The following is a description of a gene set: species: Homo sapiens Human Gene Set: GOBP_CELL_PROLIFERATION_INVOLVED_IN_HEART_MORPHOGENESIS The multiplication or reproduction of cells, resulting in the expansion of a cell population that contributes to the shaping of the heart., and this is the list of marker genes: MKS1, MIR20A (microRNA 20a), NOTCH1, TGFBR2, CTNNB1, SOX9, ENG, NACA, TBX5, SIX1, ISL1, HES1, PITX2, PIM1, BMPR2, SMAD4, EYA1, BMP10, TBX3, RBPJ, HAND2